Given this list of marker genes BMI1, CENPA, H2AC6, H2AC8, KAT6A, H2BC21, HAT1, H2AZ1, H1-2, CBX1, H2BC12, NAP1L3, BRCA2, H1-10, CHAF1A, NASP, H2AC18, SETDB1, H1-1, SATB1, H2BC11, H2AX, EZH2, H1-0, CHAF1B, H2BC13, here is a description of the gene set: studied in species Homo sapiens Genes in the cancer module 127. Human Gene Set: MODULE_127